Given this list of marker genes Spry2, Ubb, Grb2, Cbl, Mapk3, Rps27a, here is a description of the gene set: This event has been computationally inferred from an event that has been demonstrated in another species.<p>The inference is based on the homology mapping from PANTHER. Briefly, reactions for which all involved PhysicalEntities (in input, output and catalyst) have a mapped orthologue/paralogue (for complexes at least 75% of components must have a mapping) are inferred to the other species. part of: Negative regulation of FGFR1 signaling; Negative regulation of FGFR2 signaling; Negative regulation of FGFR3 signaling; Negative regulation of FGFR4 signaling electronically inferred by orthology from the curated human pathway Reactome Pathway: Spry regulation of FGF signaling studied in species Mus musculus